Given this list of marker genes RAC1, SRGAP3, SRGAP2 (SLIT-ROBO Rho GTPase activating protein 2), ROBO1, CDC42, SLIT2, ARHGAP39, SRGAP1, here is a description of the gene set: Reactome Pathway: Inactivation of CDC42 and RAC1 part of: Signaling by ROBO receptors species: Homo sapiens Rho family GTPases, including RAC1, RHOA, and CDC42, are ideal candidates to regulate aspects of cytoskeletal dynamics downstream of axon guidance receptors. Biochemical and genetic studies have revealed an important role for CDC42 and RAC1 in ROBO repulsion. ROBO controls the activity of Rho GTPases by interacting with a family of SLIT/ROBO-specific GAPs (SrGAPs) and Vilse/CrossGAP. SrGAPs inactivate CDC42 and Vilse/CrossGAP specifically inactivates RAC1.<br>It was recently implicated that SRGAP3 may inactivate RAC1 downstream of SLIT1-activated ROBO2, which promotes neurite outgrowth in mammalian dorsal root ganglion (DRG) neurons.